The following is a description of a gene set: Human Gene Set: REACTOME_SIGNALING_BY_HIPPO studied in species Homo sapiens Signaling by Hippo, and this is the list of marker genes: MOB1A, TJP1, SAV1, DVL2, MOB1B, YAP1, LATS1, AMOTL2 (NCBI Gene Id 51421), CASP3, YWHAB, AMOTL1, WWTR1, LATS2, WWC1, STK3, AMOT, STK4, YWHAE, NPHP4, TJP2